Given this list of marker genes GRB2, MMP3, HRAS, SOS1, PRKCA, HBEGF, NRAS, EGFR, KRAS, here is a description of the gene set: Reactome Pathway: EGFR Transactivation by Gastrin Gastrin, through the action of diacylglycerol produced from downstream G alpha (q) events, transactivates EGFR via a PKC-mediated pathway by activation of MMP3 (Matrix Metalloproteinase 3) which allows formation of mature HBEGF (heparin-binding epidermal growth factor) by cleaving pro-HBEGF. Mature HBEGF is then free to bind the EGFR, resulting in EGFR activation. species: Homo sapiens part of: Gastrin-CREB signalling pathway via PKC and MAPK